Given this list of marker genes POLK, H2BC14, POLQ, MRE11, ATR, H2BC7, NSD2, UBE2V2 (ubiquitin conjugating enzyme E2 V2), TP53BP1, RNF8, RNF168, MDC1, BARD1, NHEJ1, PARP2, UBXN1, EYA2, EME2, POLM, H2BC26, RAD51D, RPA2, H2BC11, FEN1, UBE2I, CDK2, H2BC4, BAP1, H2BC15, RNF4, SUMO1, UBE2N (NCBI Gene Id 7334), ABRAXAS1, BRCA1, XRCC2, ATRIP, H2BC8, TIMELESS, H4C2, LIG3, H3-4, XRCC4, POLH, BLM, TOP3A, H2BC10, XRCC3, SLX1A, TOPBP1, CHEK2, XRCC6, RAD52, XRCC5, PCNA, MAPK8, H4C3, RMI1, PPP4C, EXO1, KDM4A, EYA1, H2BC13, SIRT6, LIG4, CLSPN, BRCC3, RAD51AP1, SEM1, TP53, SPIDR, SLX4, H4C15, SMARCA5, H2BC12L, H4C5, H2AX, PALB2, PPP5C, FIGNL1, RMI2, H2BC6, POLE, UBB (NCBI Gene Id 91253), UBA52, UIMC1, APBB1, RFC3, HERC2, RAD9A, POLE4, H4C11, H4C1, RTEL1, H4C8, BABAM2, RHNO1, RPS27A, RAD51C, ATM, RIF1, WRN, CCNA1, NBN, H4C6, BRCA2, DNA2, RAD1, DCLRE1C, EYA3, TDP1, H4C9, BABAM1, PIAS4, PAXIP1, MUS81, POLD3, POLD4 (NCBI Gene Id 57804), RFC4, SUMO2, H2BC9, PPP4R2, POLD1, KPNA2, RPA1, H4C12, ABL1, CHEK1, UBC, RAD9B, KDM4B, RAD51B, KAT5, RBBP8, H4C16, ERCC4, RFC1, RAD50, H4C14, ERCC1, RAD51, TIPIN, BRIP1, BAZ1B, H2BC3, POLE3, TDP2, FIRRM, H4C4, H2BC17, H2BC5, RAD17, RFC2, GEN1, PARP1, SLX1B, EME1, POLL, H2BC12, EYA4, H2BC21, POLE2, H2BC1, XRCC1, POLD2, PRKDC, RFC5, RPA3 (NCBI Gene Id 6119), HUS1, H4C13 (H4 clustered histone 13), CCNA2, here is a description of the gene set: studied in species Homo sapiens DNA Double-Strand Break Repair Human Gene Set: REACTOME_DNA_DOUBLE_STRAND_BREAK_REPAIR